The following is a description of a gene set: from publication Barrier A, Lemoine A, Boelle PY, Tse C, Brault D, Chiappini F, Breittschneider J, Lacaine F, Houry S, Huguier M, Van der Laan MJ, Speed T, Debuire B, Flahault A, Dudoit S (PMID 16091735) This study assessed the possibility to build a prognosis predictor, based on microarray gene expression measures, in stage II and III colon cancer patients. Tumour (T) and non-neoplastic mucosa (NM) mRNA samples from 18 patients (nine with a recurrence, nine with no recurrence) were profiled using the Affymetrix HGU133A GeneChip. The k-nearest neighbour method was used for prognosis prediction using T and NM gene expression measures. Six-fold cross-validation was applied to select the number of neighbours and the number of informative genes to include in the predictors. Based on this information, one T-based and one NM-based predictor were proposed and their accuracies were estimated by double cross-validation. In six-fold cross-validation, the lowest numbers of informative genes giving the lowest numbers of false predictions (two out of 18) were 30 and 70 with the T and NM gene expression measures, respectively. A 30-gene T-based predictor and a 70-gene NM-based predictor were then built, with estimated accuracies of 78 and 83%, respectively. This study suggests that one can build an accurate prognosis predictor for stage II and III colon cancer patients, based on gene expression measures, and one can use either tumour or non-neoplastic mucosa for this purpose. Human Gene Set: BARRIER_CANCER_RELAPSE_TUMOR_SAMPLE_UP Up-regulated genes in tumor samples from colon cancer patients who developed recurrence of the disease. studied in species Homo sapiens, and this is the list of marker genes: H2AZ1, ATG12, MRPL24 (NCBI Gene Id 79590), DNAJB9, HSPA13, CXCL8, PDCD10, ATP6V1G1, MED21, LYN, ATP6V0E1, CKS1B, COPS4, MMP12 (matrix metallopeptidase 12), DCTN3, ZFAND1